Given this list of marker genes WNT3, SLC4A11, NR6A1, PDGFRA, LTBP3, SOX6, SOX5, FZD1, SOX9, GSK3B, REST, here is a description of the gene set: studied in species Homo sapiens Human Gene Set: GOBP_REGULATION_OF_MESENCHYMAL_STEM_CELL_DIFFERENTIATION Any process that modulates the frequency, rate or extent of mesenchymal stem cell differentiation.